The following is a description of a gene set: Triggering of B cell receptors (BCR) induces a massive synthesis of NFATc1 in splenic B cells. By inactivating the Nfatc1 gene and re-expressing NFATc1 we show that NFATc1 levels are critical for the survival of splenic B cells upon BCR stimulation. NFATc1 ablation led to decreased BCR-induced Ca++ flux and proliferation of splenic B cells, increased apoptosis and suppressed germinal centre formation and immunoglobulin class switch by T cell-independent antigens. By controlling IL-10 synthesis in B cells, NFATc1 supported the proliferation and IL-2 synthesis of T cells in vitro and appeared to contribute to the mild clinical course of Experimental Autoimmune Encephalomyelitis in mice bearing NFATc1-/- B cells. These data indicate NFATc1 as a key factor controlling B cell function. from publication Bhattacharyya S, Deb J, Patra AK, Thuy Pham DA, Chen W, Vaeth M, Berberich-Siebelt F, Klein-Hessling S, Lamperti ED, Reifenberg K, Jellusova J, Schweizer A, Nitschke L, Leich E, Rosenwald A, Brunner C, Engelmann S, Bommhardt U, Avots A, Müller MR, Kondo E, Serfling E (PMID 21464221) Human Gene Set: GSE21063_WT_VS_NFATC1_KO_8H_ANTI_IGM_STIM_BCELL_UP studied in species Homo sapiens Genes up-regulated in B lymphocytes stimulated by anti-IgM for 8h: wildtype versus NFATC1 knockout., and this is the list of marker genes: CALM3, CKS2, IARS1, KIF22 (NCBI Gene Id 728037), HLA-DMB, ITGB7 (NCBI Gene Id 3695), DNAJC18, H2AX, TPX2, ECT2, NCF4, CCNB1, CDC6, ENO3, AP2B1, AKIP1, SLC27A2, CCNE2, RFC3, PIF1, ZEB1-AS1, PARPBP, NUF2, TTK, DTYMK, HYLS1, ASF1B, NCAPH, C17orf58, MELK, TARS1, ATF3, CLN6, GINS2, BUB1, HCFC1, CBR3, NCALD, WDR12, FABP5, GGH, DMC1, TESC, ACOT13, DEPDC1B, AURKB, FARS2, SPC24, TMEM106C, TMEM237 (transmembrane protein 237), PLD6, POLA2, RHEBL1, GM2A, TFDP1, KIF15, HJURP, BDH1, RFC4, GZMA, IFI27L1, KCNK5, DTL, SPAG5, TUBB (NCBI Gene Id 95295), DLGAP5, BIRC5, MTHFD1, LRRC20, PSMD14, YEATS4, ACAP1, MNAT1, CSF1, MCM5, THOP1 (NCBI Gene Id 92731), DLEU1, NDC80, DENND10 (DENN domain containing 10), RAP1GDS1, PLAAT3, PHPT1, CDCA7, NCR3, KIFC1, KIF2C, TACC3, LMNB2, AARS1 (NCBI Gene Id 16), SAPCD1, SRI, SERPINB6, SUV39H2, PSAT1, ATG5, UCK2, DOCK2, RAD51, STYXL1, E2F8, EZH2, PRIM1, RTCA, FAM83D, ANLN, CPOX, NUP210, FBXO5, BLVRB, POC1A, HMGB3, CDCA2, TIPIN, HIRIP3, CHEK1, MAIP1, CENPL, MAPKAPK3 (MAPK activated protein kinase 3), PRPS2, SAE1, ALG8, ORC6, TMA16, DONSON, LACTB2, CKS1B, CHEK2, CD244, CDC25A, VANGL1, H1-10, DLAT, BUB1B, MCM6, FAF1, XPOT, DBF4, RBBP8, MBOAT1, CCNA2, SKA2, ERI1, HYCC1, EXO1, UBE2T, DIAPH3, DERA, CENPO, LIMA1, SFXN1, SDC4, E2F7, CCDC50, TMEM14A (transmembrane protein 14A), MTHFD1L, TSPAN5, CDPF1, DCPS, TMEM121, ZNF367, DMAC1, CCR2, UCHL5, GPT2, GMDS, CDK1, KIF11, CCNE1, SEPTIN8, ATP6V1B2, POGLUT2, AUH, CGAS, VRK1, TYMS, SKA1, NTAQ1, SAP30, SNX5, KIF18B, PRC1, MCM10, TOP2A, DUSP6, LRR1, MKI67, ITGAL, INPP4B, AURKA, ASPM, DHFR, HLA-DRB6, RNF187 (ring finger protein 187), MAD2L1 (mitotic arrest deficient 2 like 1), RAD54L, ELOVL6, TCEA1, PRKCB (protein kinase C beta), GPRIN3